The following is a description of a gene set: The orderly movement of a smooth muscle cell from one site to another, often during the development of a multicellular organism. species: Homo sapiens Human Gene Set: GOBP_SMOOTH_MUSCLE_CELL_MIGRATION, and this is the list of marker genes: ADIPOQ, MIR665, MIR221, PDGFD, S100A11, PDGFA, CCN4, MIR1298, SERPINE1, FOXO4, CCN3, AAMP, MAP3K7, MIR214, MIR451A, VTN, CCL5, XBP1, NDRG4, DDR1, MIR218-1, TRIB1, MIR137, MIR34A, MIR182, PRKG1, NF1, FGF9, DOCK7, NRP1, NR4A3, MIRLET7B, MIR424, NFE2L2, SEMA6D, CORO1B (NCBI Gene Id 57175), PAK1, POSTN, BMPR1A, TERT, PDGFRB, MEF2C, MIR26A1, MIR638 (microRNA 638), MIR362, FAT1, ADAMTS1, MIR143, MIR499A, MIR135B, LPAR1, MDM2, MIR146A, PARVA, MYOCD, GRB10, IGF1, ITGB3, LRP1, IGFBP3, DOCK4, DOCK5, ITGA2, IGFBP5, MDK, SSH1, MIR140, MIR302C, TLR4, MIR448, SLIT2, DDIT3, CRK, ACE, GSTP1, MIR20A, AIF1, GNA12, PDGFB, BMP4, PPARD, BCL2, MIR503, TPM1, MIR223, MIR21, PLAT, DDR2, PTPN1, ABHD2, MIR15A, SORL1, HAS2, TACR1, PLXNA1, PLAU